Given this list of marker genes Col2a1, Sdc2, Klf4, Nwd2, Inpp5a, Nfia, Gc, Camsap2, Col3a1, Pan2, Klf6, Sertad2, Gria3, Col6a3, Ppm1e (NCBI Gene Id 327991), Cpsf7, Il1rap, Fbn2, Eloc, Scai, Klhl28, Rnf19a, Adamts2, Kcnip2, Klhl34, Eml6, Csde1, N4bp2l1, Gxylt2, Smok3a, Fut8, Dbt, Frat2, Chrna4, Fbn1, Syndig1, Pi15, Ctsk, Trhde, Cps1, Apaf1 (NCBI Gene Id 76129), Scn2b (sodium channel, voltage-gated, type II, beta), Tet1, Dip2c, Dop1a, Smad6, Rps6kb1, Nlk, Scmh1, Phtf2, Isl1, Klf2, Ttc9, Ifi30, Ankrd13b, Adamts18, Col4a5, Stmn2, Usp6nl (NCBI Gene Id 98910), Adam19, Hycc2, Foxj2, Smap1, Oca2, Tbl1xr1, Stk38, A530016L24Rik, Rims2, Tet2, Tubb2a, Peg10, Hecw1, Mycn, Pcdhb16, Plekha3, Crispld1 (cysteine-rich secretory protein LCCL domain containing 1), Cacna2d3, Plxnc1, Basp1, Zfhx4, Ccnyl1 (cyclin Y-like 1), Smpd3, Pdgfa, Garre1, Oxtr, Bach2, Hmcn1, Mosmo, Ppp4r3b, Mtfmt, Akap5, Arvcf, Wdfy1 (WD repeat and FYVE domain containing 1), Otud7a, Pafah1b1, Ddx5, Pmp22, Xkr4, Morf4l2, Sestd1, Dusp2, Larp4b, Fnip2, Cux1, Eif4e2, 1700028K03Rik, Dnmt3a, Camkk2, Col11a1, Col5a2, Ahr, Zmym4, Proser1, Mbnl3, Otud4, Grip1, Taf5, Atrn, Ppm1d, Dpysl5, Tnrc18, Prkdc, Asxl3, Nap1l5, Elovl6, Jchain, Sppl2b (NCBI Gene Id 73218), Tmem169, Tll1, Adamts17, Adamts3, Cbll1, Hoxd10, Lmnb1, here is a description of the gene set: Genes predicted to be targets of miRBase v22 microRNA mmu_miR_767 in miRDB v6.0 with MirTarget v4 prediction scores > 80 (high confidence targets). from publication Chen Y, Wang X (PMID 31504780) studied in species Mus musculus Mouse Gene Set: MIR_767